Given this list of marker genes CASP5, IL18, GSDMD, CASP3, IL1B, here is a description of the gene set: species: Homo sapiens Reactome Pathway: CASP5-mediated substrate cleavage Caspase-5 (CASP5), like CASP4, is activated by cytosolic bacterial lipopolysaccharide (LPS). Once activated, CASP5 cleaves gasdermin D (GSDMD), a substrate also targeted by CASP1, CASP4, and Casp11, a murine homolog of human CASP4 and CASP5 (Shi J et al., 2014, 2015; Kayagaki N et al., 2015; Wang K et al., 2020). The cleavage at aspartic acid residue 275 (D275) within the central linker region of GSDMD releases a cytotoxic 31-kDa N-terminal fragment (GSDMD(1–275)) and a 22-kDa C-terminal fragment (GSDMD(276–484)). The N-terminal fragment has pore-forming activity, inserting into lipid membranes to form 10–16 nm pores, which ultimately drive pyroptotic cell death (Liu X et al., 2016; Ding J et al., 2016; Sborgi L et al., 2016; Aglietti RA et al., 2016; Feng S et al., 2018). The C-terminal fragment maintains an autoinhibitory interaction with the N-terminal domain in full-length GSDMD, and its cleavage by inflammatory caspases, CASP1, CASP4, or CASP5, releases this inhibition, enabling pyroptosis (Shi J et al. 2015; Ding J et al. 2016; Liu Z et al. 2019; Yang J et al. 2018; Kuang S et al. 2017; Wang K et al., 2020). Similar to CASP4, CASP5 directly cleaves pro-inflammatory cytokines of the interleukin-1 (IL-1) family, including pro-IL-18 and pro-IL-1β, exhibiting distinct substrate preferences. CASP5 efficiently cleaves pro-IL-18 at D36, producing the mature, biologically active cytokine (Shi X et al., 2023; Devant P et al., 2023; Exconde PM et al., 2023). Structural and biochemical analyses revealed that this cleavage relies on a bivalent recognition mechanism, in which pro-IL-18 binds CASP4/CASP5 through two interfaces: the protease exosite binds a hydrophobic pocket within pro-IL-18, while the active site of caspase engages charged residues located within and adjacent to the tetrapeptide recognition motif in the pro-domain (Shi X et al., 2023; Devant P et al., 2023). In contrast, CASP5 cleaves pro–IL‑1β at D27, producing an inactive fragment that lacks receptor-stimulating activity (Exconde PM et al., 2023; reviewed by Exconde PM, 2024). CASP5 may also contribute to pro-IL-1α processing and maturation (Wiggins KA et al., 2019). Mature IL-1 cytokines are released through GSDMD pores, amplifying the inflammatory response in mammals (Shi J et al., 2015; Kayagaki N et al., 2015; reviewed by Broz P et al., 2020; Liu X et al., 2021). part of: Non-canonical inflammasome activation